The following is a description of a gene set: Mouse Gene Set: GOBP_RESPONSE_TO_AUDITORY_STIMULUS Any process that results in a change in state or activity of a cell or an organism (in terms of movement, secretion, enzyme production, gene expression, etc.) as a result of an auditory stimulus. species: Mus musculus, and this is the list of marker genes: Atp1a2, AU040320, Tifab, D130043K22Rik, Gap43, Stra6, Neurog1, Kcnq2, Tacr1, Cntnap2, Calb1 (calbindin 1), Atp8a2, Foxp2, Abhd12, Nrxn2, Drd2, Shank3, Mdk, Kcnc1, Slc1a3, Atoh7, Usp53, Nrxn1, Xpc, Kcnq3, Scn11a, Slc26a5, Slitrk6, Htt, Ptn, Ucn, Abl2